The following is a description of a gene set: Human Gene Set: GOBP_MOTOR_NEURON_MIGRATION The orderly movement of a motor neuron from one site to another. A motor neuron is an efferent neuron that passes from the central nervous system or a ganglion toward or to a muscle and conducts an impulse that causes movement. studied in species Homo sapiens, and this is the list of marker genes: LHX1, NRP1, NTN1, ASCL1, FZD3, DAB1, PHOX2B, RELN, TBX20, CELSR2, NEUROD4, VEGFA, OLIG3